Given this list of marker genes PLA2G7, LDLR (low density lipoprotein receptor), APOO, APOA5, APOF, APOM, SELENOS, LSR, MSR1, APOBR, APOC2 (NCBI Gene Id 344), APP, APOE, APOA4, APOA1, APOB, here is a description of the gene set: Human Gene Set: GOCC_LOW_DENSITY_LIPOPROTEIN_PARTICLE species: Homo sapiens A lipoprotein particle, rich in cholesterol esters and low in triglycerides that is typically composed of APOB100 and APOE and has a density of 1.02-1.06 g/ml and a diameter of between 20-25 nm. LDL particles are formed from VLDL particles (via IDL) by the loss of triglyceride and gain of cholesterol ester. They transport endogenous cholesterol (and to some extent triglycerides) from peripheral tissues back to the liver.